Given this list of marker genes HSD11B1, ID2, CTAG1B, ZNF415, IL33, KLRC1, ZNF266, MMP3, SIM2, GTF2H2, CHRNA6, FUT4, ITSN1, IL13RA2, ZIC3, CTAG2, TNNI3, here is a description of the gene set: Down-regulated genes in U87 cells (glioblastoma multiforme, GBM) engineered to stably express LGI1. Disruptions of LGI1 in glioblastoma (GBM) cell lines and LGI1 mutations in families with autosomal dominant epilepsy imply a role for LGI1 in glial cells as well as in neurons. Although we and others could not find LGI1 mutations in malignant gliomas, our initial studies appeared to support the idea that LGI1 is poorly expressed or absent in these tumors. Microarray data suggested that LGI1 could be involved in the control of matrix metalloproteinases, and we found that tumors derived from U87 glioblastoma cells overexpressing LGI1 were less aggressive than U87 control tumors. To our surprise, we observed that LGI1 expression after differentiation of murine neural stem cells was robust in neurons but negligible in glial cells, in agreement with immunohistochemistry studies on rodent brain. This observation could suggest that the variable levels of LGI1 expression in gliomas reflect the presence of neurons entrapped within the tumor. To test this hypothesis, we investigated LGI1 expression in parallel with expression of the neuronal marker NEF3 by real-time PCR on 30 malignant gliomas. Results showed a strong, positive correlation between the expression levels of these two genes (P < 0.0001). Thus, our data confirm that LGI1 is involved in cell-matrix interactions but suggest that its expression is not relevant in glial cells, implying that its role as a tumor suppressor in gliomas should be reconsidered. species: Homo sapiens Human Gene Set: PIEPOLI_LGI1_TARGETS_DN from publication Piepoli T, Jakupoglu C, Gu W, Lualdi E, Suarez-Merino B, Poliani PL, Cattaneo MG, Ortino B, Goplen D, Wang J, Mola R, Inverardi F, Frassoni C, Bjerkvig R, Steinlein O, Vicentini LM, Brüstle O, Finocchiaro G (PMID 16533756)